Given this list of marker genes BCR, ITGAM, SPI1, PRAM1, SYK, ITGB2, CD177, here is a description of the gene set: Human Gene Set: GOBP_REGULATION_OF_NEUTROPHIL_DEGRANULATION species: Homo sapiens Any process that modulates the frequency, rate, or extent of neutrophil degranulation.